Given this list of marker genes FCGR2A, GCLC, SLC11A1, TGFB1, DNAJC30, ELN, DYM, NCF1, LIMK1, KCNN4, RFC2, COL5A2, CFTR, MLXIPL, TMEM270, STK11, LIG4, METTL27, CEACAM6, RPS6KA3, BMPR1A, CEACAM3, SLC9A3 (solute carrier family 9 member A3), PTEN (phosphatase and tensin homolog), HFE, LTBP4, ZFX, EFEMP1, STAT3, NAA10, GTF2I, STX1A, GTF2IRD1, COL1A1, BUD23, SERPINA1, EIF4H, EDNRA, MIF, INSR, SLC6A14, DCTN4, LMNA, SLC26A9, GSTM3, FKBP6, BAZ1B, BCOR, VPS37D, COL5A1, NSUN2, PRMT7, HMOX1, CCBE1, CLCA4, MYH11, SMAD4, CLIP2, TBL2, GTF2IRD2, here is a description of the gene set: studied in species Homo sapiens Protrusion of the rectal mucous membrane through the anus. Rectal prolapse Human Gene Set: HP_RECTAL_PROLAPSE